The following is a description of a gene set: Human Gene Set: HP_ABNORMAL_DOUBLE_NEGATIVE_T_CELL_PROPORTION Abnormal increase or decrease of double-negative (DN) CD3+CD4-CD8- T cells, measured either as percentage of total CD3+ T cells in the blood, or as absolute number per microliter of blood, compared to a reference range for a given sex and age-group. These are usually measured within the TCR alpha/beta positive population. Abnormal double-negative T cell proportion studied in species Homo sapiens, and this is the list of marker genes: FASLG, FAS, CASP10, PIK3CG, FOXP3